Given this list of marker genes Hoxa1, Plxna3, Six1, Hoxb2, Sema3f, Sema3a, Hoxb1, Egr2, Nrp2 (neuropilin 2), Adarb1, Nrp1, Plxna4, here is a description of the gene set: The process in which the anatomical structure of the facial nerve is generated and organized. This sensory and motor nerve supplies the muscles of facial expression and the expression and taste at the anterior two-thirds of the tongue. The principal branches are the superficial ophthalmic, buccal, palatine and hyomandibular. The main trunk synapses within pterygopalatine ganglion in the parotid gland and this ganglion then gives of nerve branches which supply the lacrimal gland and the mucous secreting glands of the nasal and oral cavities. Mouse Gene Set: GOBP_FACIAL_NERVE_MORPHOGENESIS studied in species Mus musculus